The following is a description of a gene set: Catalysis of the movement of a monocarboxylate, any compound containing a single carboxyl group (COOH or COO-), by uniport, symport or antiport across a membrane by a carrier-mediated mechanism. Mouse Gene Set: GOMF_SECONDARY_ACTIVE_MONOCARBOXYLATE_TRANSMEMBRANE_TRANSPORTER_ACTIVITY species: Mus musculus, and this is the list of marker genes: Slc32a1, Slc5a12, Slc10a3, Slc6a11, Slc6a8, Slc10a5, Slc6a6, Slc10a4-ps, Slc16a3 (solute carrier family 16 (monocarboxylic acid transporters), member 3), Slc10a1, Slc6a1, Slc6a13, Slc10a4 (solute carrier family 10 (sodium/bile acid cotransporter family), member 4), Slc10a6, Slc5a8, Slc10a2, Slc5a6, Slc6a12, Slc16a1